Given this list of marker genes Vip, Drd4, Ednrb, Oxtr, Shh, P2ry1, Ar, P2ry2, Oxt, here is a description of the gene set: Any process that increases the rate, frequency or extent of penile erection. Penile erection is the hardening, enlarging and rising of the penis which often occurs in the sexually aroused male and enables sexual intercourse. Achieved by increased inflow of blood into the vessels of erectile tissue, and decreased outflow. studied in species Mus musculus Mouse Gene Set: GOBP_POSITIVE_REGULATION_OF_PENILE_ERECTION